Given this list of marker genes Commd1, Snx33, Astn2, Nedd4l, Picalm, Arf6, Leprot, Actn2, Gopc (NCBI Gene Id 94221), Tax1bp3, Gpm6b (glycoprotein m6b), Plk2, here is a description of the gene set: Mouse Gene Set: GOBP_NEGATIVE_REGULATION_OF_PROTEIN_LOCALIZATION_TO_CELL_SURFACE studied in species Mus musculus Any process that stops, prevents, or reduces the frequency, rate or extent of protein localization to the cell surface.